Given this list of marker genes Fyb1, Klf2, Actn2, Itgae (integrin alpha E, epithelial-associated), Arhgef1, Crip1, Thy1, Rasgrp1, Limd2, Cd8b1, Rab37, Stk10, Cd5, Ramp1, Nsg2, Macf1 (microtubule-actin crosslinking factor 1), Epsti1, Fxyd5, Cd2, Septin1, Rgcc, Rgs10, Cd3g, Actg1, Dapl1, Hspa1b, Bin2, Smpdl3a, Cd48, Ypel3, Arhgdib, Rasgrp2, Tspan32, 9930111J21Rik2, Cd226, Ms4a4b, Kif21b, Rac2, Emp3, Pitpnc1, Grap2, Add3, Myh9, Crlf3, Tecr, Id3, Btg2, Tent5a, Themis, Trbc2, Sh3bgrl3, Srpk2, Uba52, Cd96, Dnajc15, Cd28, Chd3, Scp2, Hsd11b1, Cd52, Cd8a, Smc4 (structural maintenance of chromosomes 4), Cnn2, Ms4a6b, Tbc1d10c, Ankrd44, Coro1a (NCBI Gene Id 16902), Ms4a4c, Itpkb, Hspa1a, Lbh, Lck, Flna, Grap, Actn1, Stap1, Arl5c (ADP-ribosylation factor-like 5C), Pou2f2 (NCBI Gene Id 18987), Ccr9, Tagln2, Adgre5, Itgb7, Lrrfip1, Saraf, Evl, Ccdc88c, Lef1, Septin6, Rhoh, Fam78a, Mgst2, Tubb5, Klf6, Ostf1, Ltb, Ighm, Cd27, Eno1, Ptprcap, Pycard, S100a10, Tdrp (NCBI Gene Id 72148), Clec2d, Lsp1, Cd3e, Adcy7, Tmsb10, Shisa5, Bin1, Cotl1, here is a description of the gene set: Genes negatively differentially expressed in cell type: CD8+ T cell upon treatment with cytokine: IL-1β in mouse lymph nodes in vivo. Cytokines mediate cell-cell communication in the immune system and represent important therapeutic targets. A myriad of studies have highlighted their central role in immune function, yet we lack a global view of the cellular responses of each immune cell type to each cytokine. To address this gap, the authors created the Immune Dictionary, a compendium of single-cell transcriptomic profiles of more than 17 immune cell types in response to each of 86 cytokines (>1,400 cytokine-cell type combinations) in mouse lymph nodes in vivo. A cytokine-centric view of the dictionary revealed that most cytokines induce highly cell-type-specific responses. For example, the inflammatory cytokine interleukin-1β induces distinct gene programmes in almost every cell type. A cell-type-centric view of the dictionary identified more than 66 cytokine-driven cellular polarization states across immune cell types, including previously uncharacterized states such as an interleukin-18-induced polyfunctional natural killer cell state. Mouse Gene Set: CUI_T_CELL_CD8_IL1B_RESPONSE_DN from publication Cui A, Huang T, Li S, Ma A, Pérez JL, Sander C, Keskin DB, Wu CJ, Fraenkel E, Hacohen N (PMID 38057668) studied in species Mus musculus